The following is a description of a gene set: Mouse Gene Set: GOBP_POSITIVE_REGULATION_OF_ENDOTHELIAL_CELL_DIFFERENTIATION Any process that activates or increases the frequency, rate or extent of endothelial cell differentiation. species: Mus musculus, and this is the list of marker genes: Ctnnb1, Btg1, Bmp6 (NCBI Gene Id 28108), Atoh8, Tmem100, Vezf1, Etv2, Acvrl1, Gdf2, Bmp4, Notch1